Given this list of marker genes Ppp5c, Rab3ip, Slc1a1, Nefh, Dlg4, Gria1, Grip1, Syncrip, Fmr1, Kcnab1, Kcnb1, Gigyf2, Pcsk5, Map2, Ptpn5, here is a description of the gene set: Mouse Gene Set: GOCC_PROXIMAL_DENDRITE studied in species Mus musculus The dendrite of the dendritic tree that is closest to the neuronal cell body (the soma).